Given this list of marker genes Bag3, Mapk3, Hspa14, Nup205, Nup54, Seh1l, Rae1, Hikeshi, Bag4 (NCBI Gene Id 67384), Nup58, Hspa12a, Nup85, Bag1, Hspa1l, Sirt1, Nup155, Rps19bp1, Hsf1, Dnajb6, Dnajb1, Nup133, Nup93, Ywhae, St13, Nup210, Rpa1, Ndc1, Hsph1, Hspa2, Nup42, Hspa12b, Aaas, here is a description of the gene set: species: Mus musculus This event has been computationally inferred from an event that has been demonstrated in another species.<p>The inference is based on the homology mapping from PANTHER. Briefly, reactions for which all involved PhysicalEntities (in input, output and catalyst) have a mapped orthologue/paralogue (for complexes at least 75% of components must have a mapping) are inferred to the other species. part of: Cellular response to heat stress Reactome Pathway: Regulation of HSF1-mediated heat shock response electronically inferred by orthology from the curated human pathway